Given this list of marker genes ZMYND15, YWHAB, MEF2B, MEF2A, SKOR2, MIER1, KCTD21, MAGEA6, MAGEA8, TBX2, THAP7, TP53 (tumor protein p53), BLTP3A, MEF2D, TRAF6, BHLHE41, INSM1, CDC20, HES1, HDAC6, MEF2C, MIER3, CAMTA2, CBX5, NR2C1, CHD4, HOXA10, PHF6, KLF4, CRY1, HSPA1A (heat shock protein family A (Hsp70) member 1A), MAGEA10, ZNHIT1, RELA, CIITA, HIC1, ANKRD1, NR2E1, KAT2B, MIER2, BRMS1L (NCBI Gene Id 84312), MTA2 (metastasis associated 1 family member 2), JDP2, NIPBL, BRMS1 (BRMS1 transcriptional repressor and anoikis regulator), SP2, SIK1, HSP90AA1, NCOR2, MAGEA2, H1-5, MAGEA2B, SIX3, MAGEA9, SIRT2, SRF, ANKRA2, CEBPA, BCOR, SPI1, TAL1, PHB1, FOXP3, RFXANK, SP1, HDAC9, YWHAE, TCF21, H1-4, AKAP8, NKX3-1, PKN1, MTA3, PARP1, DHX36, HNRNPD, KAT2A, LCOR, TFAP4, NRIP1, MAGEA3, CCND1 (cyclin D1), NCOR1, HDAC4, SUDS3, MAPK8, CIR1, BEX4, HSPA1B, SMG5, HIF1A, HDAC10, MAGEA9B, HSP90AB1 (NCBI Gene Id 3326), RBBP4, BCL3, WDTC1 (NCBI Gene Id 23038), PKN2, NUDT21, NACC2, PRKN, HDAC3, MAGEA11, HDAC1, AKAP8L, MAGEA4, IKZF3, SFPQ, ZBTB7B, MAGEA12, DDX20, MTA1, RARA, SATB2, GMNN, MYOCD, GCM1, DACT1, USF1, KPNA2, RAD9A, NACC1, CEBPB, BORCS8-MEF2B, MAGEA1, TWIST1, SMYD4, LEF1, HDAC2, HEY2, GLI3, HDAC5, here is a description of the gene set: Human Gene Set: GOMF_HISTONE_DEACETYLASE_BINDING Binding to histone deacetylase. species: Homo sapiens